Given this list of marker genes RARA, ARRB2, SRSF1, PINK1, BCL10, APPL1, CCDC88A, SRSF5, PDE3B, ANKRD2, TRAF6, here is a description of the gene set: Binding to protein kinase B, an intracellular kinase that is important in regulating glucose metabolism. studied in species Homo sapiens Human Gene Set: GOMF_PROTEIN_KINASE_B_BINDING